Given this list of marker genes MARK1, NQO1, RTN1, HERC2P9, MEST, STYXL1, RAB3GAP1 (RAB3 GTPase activating protein catalytic subunit 1), SLC29A2, TLE1, GTF2F1, ZNF37BP (zinc finger protein 37B, pseudogene), GPATCH2, PLOD2, KLHDC10, PATZ1, PTK7, RHOD, ZC2HC1A, ZNF654, FMO2, SRD5A3, PCGF3, ITGB3BP, LIMCH1, RETREG1, COPG2IT1, PCLO, ENPP4, ZNF322, PMS2, IL20RA, RABIF, HS3ST2, EIF2AK1, GUSBP3, CDR2L, CBR4, ENOSF1, ZNF606, EIF1AX, PRKG2, CKMT1B, NAIP, EIF2S1, INO80B, RPL37A, ENSG00000301761, OCLNP1, ELP5, SERF1A, SCCPDH, CSGALNACT1, RABEP1, PKIA, TSGA10, EIF2S3, PLG, PYGL, DHFR (NCBI Gene Id 203373), ARL17A, TRIM2, INHBB, ARL17B, RBM3, ZNF467, PDE3B, MTMR2, TP53TG3, USP6, CELF1, GUSBP14, LGALS8, GLTP, ADI1, ZMYND8, ZNF443, CHKA (NCBI Gene Id 1119), VANGL1, NARS2, MAPK8, NPEPPS, EFL1, VPS53, SLC39A4, PIK3CA, ADRB1, ELOVL6, ST20, FRK, here is a description of the gene set: The incidence and mortality rates of prostate cancer are significantly higher in African-American men when compared with European-American men. We tested the hypothesis that differences in tumor biology contribute to this survival health disparity. Using microarray technology, we obtained gene expression profiles of primary prostate tumors resected from 33 African-American and 36 European-American patients. These tumors were matched on clinical variables. We also evaluated 18 nontumor prostate tissues from seven African-American and 11 European-American patients. The resulting datasets were analyzed for expression differences on the gene and pathway level comparing African-American with European-American patients. Our analysis revealed a significant number of genes, e.g., 162 transcripts at a false-discovery rate of <or=5% to be differently expressed between African-American and European-American patients. Using a disease association analysis, we identified a common relationship of these transcripts with autoimmunity and inflammation. These findings were corroborated on the pathway level with numerous differently expressed genes clustering in immune response, stress response, cytokine signaling, and chemotaxis pathways. Several known metastasis-promoting genes, including autocrine mobility factor receptor, chemokine (C-X-C motif) receptor 4, and matrix metalloproteinase 9, were more highly expressed in tumors from African-Americans than European-Americans. Furthermore, a two-gene tumor signature that accurately differentiated between African-American and European-American patients was identified. This finding was confirmed in a blinded analysis of a second sample set. In conclusion, the gene expression profiles of prostate tumors indicate prominent differences in tumor immunobiology between African-American and European-American men. The profiles portray the existence of a distinct tumor microenvironment in these two patient groups. studied in species Homo sapiens Human Gene Set: WALLACE_PROSTATE_CANCER_RACE_DN from publication Wallace TA, Prueitt RL, Yi M, Howe TM, Gillespie JW, Yfantis HG, Stephens RM, Caporaso NE, Loffredo CA, Ambs S (PMID 18245496) Genes down-regulated in prostate cancer samples from African-American patients compared to those from the European-American patients.